The following is a description of a gene set: Catalysis of a reaction that alters the conformation or assembly of a polypeptide. species: Homo sapiens Human Gene Set: GOMF_POLYPEPTIDE_CONFORMATION_OR_ASSEMBLY_ISOMERASE_ACTIVITY, and this is the list of marker genes: PSMC4, DNAH17, DNAH10, DNAH3, MYO9B, MYH6, DNAL4, KIF21B, MYL6, DYNC1I2, DNAH5, KIF5B, STARD9, DNAH2, KATNA1, APPBP2, MYO1B (NCBI Gene Id 92451), KIFC1, KIF15, KIF4A (kinesin family member 4A), DNAH7, MYO1C, MYO1A, MYO6, DYNLRB1, KIF27, MYH14, MYO5C, KIF1B, MYH2, FIGNL2, KIF1A, MYH11, KIFC3, DYNC1I1, FIGNL1, KIF18A, PSMC1, CFTR, KATNAL1, KIF26B, PSMC5, KIF3A, MYH1, DNAH14, TNNT2, KIF17, MYO1F, MYO1G, KIF26A, MYO1H, KIF16B, MYO3B, KIF22, DYNC2H1, KIF2A, PSMC3, KIF2C, DNAH1, KIFC2, MYO3A, SMC3, MYH13 (NCBI Gene Id 8735, myosin heavy chain 13), DNAI2, DNAH11, MYH9, KIF18B, MYO1D, DNAH6, MYH8, MYH3 (myosin heavy chain 3), KIF28P, DNAH9, MYH7B, MYO10, MYO19, MYO7A, SPAST, MYO1E, MYO15A, DNHD1, MYO5B, MYH15, MYH4, MYH10, KIF19, KATNAL2, KIF20B, DNAH12, KIF2B, KIF14, MYH7, MYO5A, KIF20A (kinesin family member 20A), DYNC1H1, KIF23, KIF21A, KIF5A, PSMC2, KIF9, KIF6, ACTC1 (actin alpha cardiac muscle 1, NCBI Gene Id 70), MYO7B, DYNLRB2, KIF7, IQCA1L, DNAH8, KIF11, KIF5C, KIF13B, KIF12, MYO9A, FIGN, KIF3B (NCBI Gene Id 9371), PSMC6, KIF3C, CENPE, KIF4B, IQCA1, KIF1C, KIF25, KIF24, KIF13A